Given this list of marker genes VCL, MBOAT2, EI24, YWHAQ, NR6A1, SPOCK2, TENT4A, RAB3C, TRIO, LINGO1 (NCBI Gene Id 84894), XPO7, VGLL4, COPS7B, GRIP2, KCNA1, NUCKS1, CCDC80, MLEC, RAB9B, VANGL1, THEM5, STX2, CNOT2, MAPKBP1, PFKFB3, CADM2, RETREG2, SYS1, FAM120C, SNPH, TNR, SSR1, PDE7A, PIK3AP1, PDXK, PACS2, SH2B3, ARF3, NF2, MAPK8IP1, CCDC136, ZNF672, ICMT, THY1, POU4F1, ADAMTSL4, WIPF3, CDK16, SLC43A2, NR4A3, SLC25A37, MACC1, SLC30A7, SCAMP2, IRGQ, CBX5, CD300LG, GABBR2, VDR, GLG1, ATXN1, TBL1Y, ZBTB47, SSH2, CTNNA3, KIAA0930, JPH4, SLC12A6, SV2B, GARRE1, ZBTB21, AMFR, PCCB, NECTIN1, ATP1B2, NDUFB4, LHPP, NSD1, ASXL1, C9orf152, CSF1, RHOA, COL5A3, MFSD14B, RNF169, FAM227A, KCND2, MOB3B, GYPE, LIFR, NFASC, SLC12A5, RIMS4, TUB, ASPHD2, SUPT6H, RAB35, TMCC1, BAIAP2, SH3PXD2B, STMN2, ETV6, ANKRD63, ST8SIA2, ETF1, PITPNM2, DCAF10, MYO15A, PRKN, NCOA4 (NCBI Gene Id 8031), SEMA3F, USP9X, IQCJ-SCHIP1, MOSPD3, ZNF609, HMGN3, SOX6, ESRRG, ZDHHC9, C2orf68, EFNA1, PEA15, BACH2, TEAD3, TOM1L2, TMEM201, PCBD2, STIM1, PPM1M, NHSL1, GPR153, ANK1, SLC24A2, SCN4A, MAP3K9, HAPLN1, PDE3A, MAVS, RANBP10, SIRPB1 (NCBI Gene Id 93149), CFL2, CASTOR2, RANGAP1, PPFIA2 (NCBI Gene Id 8499), ZNF608, PDZRN3, AP1M2, PGAM1, CKMT2, PARD3B, ZC4H2, TRAF6, YPEL1, CBFA2T2 (NCBI Gene Id 9139), SLC25A45, VCF2, STARD3, HDGFL2, TRIM33, FBXL20, HEATR1, ZNF592, ARHGAP1, HS3ST3B1, STEAP2, DEPTOR, CAMSAP2, ANKS1B, MORN4, PTPN12, ABCC5, KIF18B, GUF1, HLF, FSTL4, CACNA1B, DIP2B, SLC24A3, FHIT, TAF9B, SLC4A7, here is a description of the gene set: Human Gene Set: MIR6808_5P species: Homo sapiens from publication Chen Y, Wang X (PMID 31504780) Genes predicted to be targets of miRBase v22 microRNA hsa-miR-6808-5p in miRDB v6.0 with MirTarget v4 prediction scores > 80 (high confidence targets).